The following is a description of a gene set: studied in species Mus musculus The assembly of a bleb, a cell extension caused by localized decoupling of the cytoskeleton from the plasma membrane and characterized by rapid formation, rounded shape, and scarcity of organelles within the protrusion. Plasma membrane blebbing occurs during apoptosis and other cellular processes, including cell locomotion, cell division, and as a result of physical or chemical stresses. Mouse Gene Set: GOBP_BLEB_ASSEMBLY, and this is the list of marker genes: Emp3, Actr3, P2rx7, Emp2, Anln, Mylk, Ano6, Lpar3, Prdx6, Emp1, Pmp22, Rock1, Lpar1